Given this list of marker genes GATA4, ISL1, SMAD1 (NCBI Gene Id 4086), SMYD1, KAT5, TBX20, SRF, NKX2-5, LEF1, LDB1, GATA6, SMAD4, EOMES, CTNNB1, MYOCD, TBXT, TBX5 (T-box transcription factor 5), MEF2C, HEY1 (NCBI Gene Id 23462), TBX1, FOXO4, WDR5, MESP1 (mesoderm posterior bHLH transcription factor 1), HEY2, HAND2, HAND1, KAT2A, here is a description of the gene set: part of: Developmental Biology studied in species Homo sapiens Gradients of Bone Morphogenetic Protein (BMP), Wingless-related integration site (WNT), and NODAL promote the formation of cardiac progenitors anteriolateral to the primitive streak during gastrulation. Eomesodermin (EOMES) and TBXT (T, Brachyury) expressed in the cardiac mesoderm activate expression of MESP1, a master regulator of cardiogenesis and the first observed marker of cardiac progenitors. MESP1-expressing cells migrate anteriorly towards the midline to form the cardiac crescent posterior to the head folds at about 2 weeks of gestation in humans (E7.5 in mice).<br><br>Within the cardiac crescent, two populations of cells can be identified based on gene expression and timing of contribution to the developing heart: the first heart field (FHF) forms the initial heart tube and contributes to the systemic ventricle (the left ventricle in crocodilians, birds, and mammals), the septum, and, to a lesser extent, the atria; the second heart field (SHF) extends the poles of the heart and contributes to the atria, the outflow tract, the septum, and the right ventricle, which is responsible for pulmonary circulation and distinguishes crocodilians, birds, and mammals.<br><br>At about 3 weeks gestation in humans (E8 in mice), FHF cells migrate axially to the midline and fuse to form the heart tube. Elongation of the heart tube leads to rightward looping and eventual formation of atria and ventricles. FHF cells do not proliferate as much as SHF cells and mostly differentiate into cardiomyocytes due to the actions of myocardial differentiation factors such as NKX2-5, GATA4, TBX5, and HAND1. SHF cells are initially located in the posterior region of the cardiac crescent then, during formation of the heart tube, become located at the arterial and venous poles of the heart tube. SHF cells proliferate more than FHF cells and can differentiate to form cardiomyocytes, endothelial cells, smooth muscle cells, and fibroblasts. A reservoir of SHF progenitors located at the core of the pharyngeal mesoderm continuously contributes to the developing heart. Proliferating SHF cells express FGF8 and FGF10 driven by ISL1 and TBX1.<br><br>Cardiac progenitors are regulated by a distinct set of transcription factors and mutations in these factors and other factors involved in gene expression are responsible for congenital heart defects. Additionally, combinations of these transcription factors are now being used to reprogram fibroblasts and other cell types into cardiomyocytes for repairing damaged hearts. TBXT (T, Brachyury) is expressed early in developing mesoderm and is activated by WNT signaling, which maintains proliferation and is subsequently downregulated during differentiation. Activation of MESP1 expression by TBXT and EOMES occurs early in gastrulation. MESP1 is expressed in both the FHF and the SHF. MESP1, in turn, directly activates two key regulators of cardiac development: GATA4 and NKX2-5 (NKX2.5, the ortholog of Tinman in Drosophila). Bone Morphogenetic Protein (BMP) signaling originating from BMPs secreted by underlying endoderm also enhances expression of GATA4 and NKX2-5, apparently through binding of SMAD proteins to the promoters of GATA4 and NKX2-5. GATA4 and NKX2-5 proteins, in turn, regulate each other's expression and directly interact to regulate downstream target genes. NKX2-5 directly activates GATA6 throughout the cardiac mesoderm.<br><br>The FHF is characterized by expression of TBX5 and HCN4; the SHF is characterized by transient expression of TBX1, ISL1, FGF8, FGF10, and SIX2. In the FHF, NKX2-5 binds the promoter of the TBX5 gene and activates transcription. TBX5, in turn, directly activates expression of SRF. TBX5 protein interacts directly with NKX2-5 and GATA4 proteins to activate further downstream targets. Sonic hedgehog (SHH) from the pharyngeal endoderm and WNT signaling maintain proliferation of SHF cells, In the SHF, TBX1, GATA4 and LEF1:CTNN1 (LEF1:Beta-catenin from Wnt signaling) directly activate ISL1, characteristic of SHF cells, and ISL1 then activates expression of HAND2 (dHAND), also characteristic of SHF cells. Reactome Pathway: Cardiogenesis